Given this list of marker genes FLT3, here is a description of the gene set: part of: Drug resistance of FLT3 mutants species: Homo sapiens Linifanib is a type I tyrosine kinase inhibitor with activity against a broad range of receptor tyrosine kinases including FLT3. This pathway describes FLT3 mutants that are resistant to inhibition by linifanib. Reactome Pathway: linifanib-resistant FLT3 mutants